Given this list of marker genes Mad2l2, Shld2 (NCBI Gene Id 75698), Il27ra, Prkdc, Il13ra1, Tnfrsf4, Mir181b-1, Cd37, Traf2, Zpbp2, Il21, Rbp4, Tbx21, Supt6, Ndfip1, 6030468B19Rik, Tlr9, Trex1, Hmces, Shld1, Cd28, Xcl1, Fcgr2b, Phb2, Sash3, Hpx, Ptprc (NCBI Gene Id 19264), Il33, Aplf, Stat6, Cd40, Cd40lg, Tnf, Tgfb1, Il2, Msh2 (NCBI Gene Id 17685), Xbp1 (X-box binding protein 1), Foxp3, Il6, Pms2, Galnt2, Il10, Pkn1, Btk, Siglecg (NCBI Gene Id 243958), Il2rg, H2-T23, Lilrb4a, Kmt5c, Shld3, Cgas, Dnajb9, Tmbim6, Foxp1, Nsd2, Cd27, Il4, Phb1, Cd22, Il13ra2, Tnfsf13, Tfrc, Exosc6, Slc15a4, Parp3, Ephb2, BC037156, Il4ra, Atad5, Gpi1, Mlh1, Mir181b-2, Clcf1, Ifng (interferon gamma), Mzb1, Ifnb1, Traf6, Tnfaip3, Ighm (NCBI Gene Id 432703), Il13, Rif1, Kmt5b, Exosc3, Stx4a, Cd86, Tnfsf4, Il5, Vpreb3, Paxip1, Bcl6 (B cell leukemia/lymphoma 6), Trp53bp1 (NCBI Gene Id 27223), Pagr1a, here is a description of the gene set: Mouse Gene Set: GOBP_REGULATION_OF_IMMUNOGLOBULIN_PRODUCTION Any process that modulates the frequency, rate, or extent of immunoglobulin production. studied in species Mus musculus